The following is a description of a gene set: Human Gene Set: GNF2_RAN species: Homo sapiens Neighborhood of RAN Neighborhood of RAN RAN, member RAS oncogene family in the GNF2 expression compendium, and this is the list of marker genes: IARS1, CCT4, MRPL42, ATIC, IMMT, MSH6, NAE1, MTHFD2, PRKDC, PSMD14, GMPS, NCAPD2, CCT3, ADSL, XRCC5 (X-ray repair cross complementing 5), SNRPE, PSMA4, PSMA5, MRPL3, KIF20A, SSBP1, PSMA3, CSE1L, C1QBP, BANF1, H2AZ1, CCT5, ABCE1, MRPL35, CDC20, MRPL15 (NCBI Gene Id 65001), CCT8, HSPA9, CCT7, MRPL22, PAICS, RTRAF, SNRPD1, MRPS33, CCT2, NME1 (NCBI Gene Id 7794), TCP1, LSM4, RRM1, NOP16 (NOP16 nucleolar protein), LRPPRC, YARS1, SNRPF, SLBP, BUB3, ETFA, RFC4, SNRPC, EIF2S1 (eukaryotic translation initiation factor 2 subunit alpha), CCT6A, CKS1B, SEM1, PRMT5, SNRPD3, HNRNPA2B1, RPA3, EPRS1, SNRPD2 (NCBI Gene Id 6633), CTPS1, HNRNPC, PA2G4, SNRPG, PSMA2, RFC3, PTGES3, SLIRP, ODC1, TARS1, POLR2H, EMG1, EIF2S2, MCM3, SSRP1, RAN, MELK, OLA1, RTCA, SNRPA, GNL3, RANBP1, SERBP1